Given this list of marker genes CACNA1G, SACS, NOP56, ATXN1, TSEN54, here is a description of the gene set: Loss of Purkinje cells in the cerebellar vermis studied in species Homo sapiens Human Gene Set: HP_LOSS_OF_PURKINJE_CELLS_IN_THE_CEREBELLAR_VERMIS